The following is a description of a gene set: studied in species Mus musculus from publication Marson A, Kretschmer K, Frampton GM, Jacobsen ES, Polansky JK, MacIsaac KD, Levine SS, Fraenkel E, von Boehmer H, Young RA (PMID 17237765) Foxp3+CD4+CD25+ regulatory T (T(reg)) cells are essential for the prevention of autoimmunity. T(reg) cells have an attenuated cytokine response to T-cell receptor stimulation, and can suppress the proliferation and effector function of neighbouring T cells. The forkhead transcription factor Foxp3 (forkhead box P3) is selectively expressed in T(reg) cells, is required for T(reg) development and function, and is sufficient to induce a T(reg) phenotype in conventional CD4+CD25- T cells. Mutations in Foxp3 cause severe, multi-organ autoimmunity in both human and mouse. FOXP3 can cooperate in a DNA-binding complex with NFAT (nuclear factor of activated T cells) to regulate the transcription of several known target genes. However, the global set of genes regulated directly by Foxp3 is not known and consequently, how this transcription factor controls the gene expression programme for T(reg) function is not understood. Here we identify Foxp3 target genes and report that many of these are key modulators of T-cell activation and function. Remarkably, the predominant, although not exclusive, effect of Foxp3 occupancy is to suppress the activation of target genes on T-cell stimulation. Foxp3 suppression of its targets appears to be crucial for the normal function of T(reg) cells, because overactive variants of some target genes are known to be associated with autoimmune disease. Mouse Gene Set: MARSON_BOUND_BY_FOXP3_STIMULATED Genes with promoters bound by FOXP3 in hybridoma cells stimulated by PMA and ionomycin., and this is the list of marker genes: Ncoa3, H2bc21, Dgka, Ociad2, Cd3g, Ect2, Tnfrsf18, Hp1bp3, Marchf6, Fgl2, Ttc24, H3c8, Clec2d, Dbf4 (NCBI Gene Id 27214), Stat3, H2ac6, Eea1, Ly96, Znrf2, Kdm2b (lysine (K)-specific demethylase 2B), Fkbp1a, Hadhb, St13, Rps6ka5, Msh5, Leo1, Cntd1, Dtl, Mier1, Junb (NCBI Gene Id 16477), Coq10b, Nars2 (asparaginyl-tRNA synthetase 2 (mitochondrial)(putative)), H3c1, Lyrm4, H4c6, Tmem50a, Dap, Ctps1, Fbxw21, Anxa9 (NCBI Gene Id 93822), Cyp1a1, Ube2d3, Kif2c, Ubb, Epm2aip1 (NCBI Gene Id 77781), Ranbp10, Hsp90b1 (NCBI Gene Id 22027), Itgb7, Ndfip1, Lrr1, Cisd2 (CDGSH iron sulfur domain 2), Ern1, Cenpl, Rchy1, Wdr44, Kctd10, Hnrnpf, Nfatc2 (nuclear factor of activated T cells, cytoplasmic, calcineurin dependent 2), Usp17ld, Tmed2, Srpk1, Sytl2, Slc25a40, Gm5867, Slc26a8, Irag2, Snrnp35, H4c2, Tubg1, Cops7b, Tmed10, H4c8, Tradd, Adam10, Psme3ip1, AI504432, C1galt1, Fem1b, Zfp13, Tom1l2, 4933434E20Rik, Alyref, Gas5, Pofut1, Plin2, Letmd1, Ccni, Dipk1a, Nrip1, Zbtb11os1, Trp53, Camk1d, Limd2 (LIM domain containing 2), Mapre2, Rbl1, Orm1, Itk, Tmed5, Elavl1, Ttc5, Trim16, Atp10d, Themis (thymocyte selection associated), Acp2, Scnm1, Kifc5b, Ccr1, Fam216a, Snapc3, Frmd8, Zfp52, Rbm6, Spa17, Camk2g (calcium/calmodulin-dependent protein kinase II gamma), Reep3 (receptor accessory protein 3), Mcm3, Bin3, 2700097O09Rik, Tnfrsf19, H4c1, Mllt3, Eri2, Ubap2l, Retreg3, Dyrk1a, Trpc2, Kctd20, Stk26, Numa1, Nsfl1c, Gtpbp1, H2ac8, Lgals8, Slfn3, Mlec, Flad1, Pcsk1, Ccnd3 (cyclin D3), Bspry, Wdr6, Sema4a, Usp8, Mdm2, Lyrm1, H1f5, Fyn, Csf1, Psmb3 (NCBI Gene Id 99155), Gm5763, Ints12, Edem1, Ddx39a, Or8c16, Per1, Dnajc2, Cobll1 (NCBI Gene Id 319876, Cobl-like 1), Chek1, Pbrm1, Nckap1, Trappc5 (trafficking protein particle complex 5), Clip1, Sesn1, Smap2, Gck (glucokinase), Leprotl1, H3c14, Rest, Bbs12, Abhd2, Slc25a45, Fasl, Ndufv2, Slc37a3, Hnrnpa1, Acot2, Gpr35, Dclre1b, Nop58, Marchf9, Vps72, Tmem60, Dzip3, Rrp12, Oaz1, Enoph1, Psmc2, Trim44, Cstpp1, Stx16, Dennd1b, Apaf1, Jmjd6, Crtam, H2bc26, Sash3, Setd7, Vmn1r14, Ppat, Pdia3, Rheb, Ttc41, Adgre4, Klf6 (Kruppel-like transcription factor 6), Usp17lc, Tnfrsf9, Fam162a, Sephs1, Dclre1c, Hsd17b10, Smarcc1, Atg12, Ggta1, Rab8b, Dbr1, Ikbip, Ppie, Wdr31, Dynlt2a1, Sfr1, Tpgs2, Mink1, Traf3ip3, Myl4, Ms4a6b, Hmg20a, Ppp1r13b, Itih5, Ctsc, 4921524J17Rik, Erp27, Pde6d, Coa7, Ing3 (NCBI Gene Id 71777), Atl3, Tmem79 (NCBI Gene Id 71925), Zbtb1, Xpo1, Zc3hav1, Cdk4, Ell, Ccdc32, Usp48, Tnfsf4, Synj2, Ddias, Mfsd6, Kbtbd3, Gm14296, Mtmr1, Mdm1, Kdm5a, Mrpl36, Utp25, Tmem59, Nr1h3, H2ac22, Slc22a3 (NCBI Gene Id 20519), H3c7, H1f3, Cilk1, Cyp4f41-ps, Sypl1, Gcnt3, Map3k1, Fth1, Lipc, Arl5b, Trpc4ap, Kdm5b, Ssbp3, Dap3, Zfp36l1, Nap1l4, Flot1, Rilpl1, Slc17a6, Poglut3, Arid1a, Map2k6, Praf2, Ube3b, Supt20, Birc3, Ddit4, Herpud2, Zbtb25, Eif4e, Gimap5, Zbtb37, Pou2f3, Btbd35f7, Cab39, Nrbp1, Aqp9, Evi2b, Slc2a1, Eya2, Thumpd3, Zfp426, Nabp1, Tpst2, Tceanc2, Itgal, Hsf4, Acsl4, Ramp1, Ubb-ps (ubiquitin B, pseudogene), Pms1, Ier3, Gm5865, Ptbp3, Evi2a, Saraf, Bltp3b, Ash1l, Fars2, Six6, Wbp11, Polg2 (NCBI Gene Id 50776), Xrcc4, Plcd1, Cd72, Vtcn1, Dsg2, Fam135a, Samd13, Cited2, Rspry1, Herc4, Cbx7, Nr1d1, Kcnn4, Ermard, Pou2af1, Ptger1, Cnot2, Arih2, Pmpca, Tesk2 (testis-specific kinase 2), P2rx4, Prr13, Prune1, Rgs3, Ccdc18, Gpr18, Izumo1r, Dync2i1, Ccdc77, Samd4b, Cfap43, Commd3, Efcab2, Slc3a2, Tmod3, Arl6ip6, Dixdc1, Snai3, Grap, Cpd, Uba3, Il2, Plg, Eapp, H4c3, Gstt2, Rnf170, Mrgpra2b, Gbp8, Wrap53, Zfand6, Xbp1, Cdk19, H3c10, Rab19, Psen1, Xlr5d-ps, Avpi1, Tiparp, Ubxn8, H2ac4, Arf2, Atp5if1 (ATP synthase inhibitory factor subunit 1), Tbce, BC049715, Cutal (cutA divalent cation tolerance homolog-like), Utp6 (NCBI Gene Id 216987), Srp54a, Gpr171, Slc20a1, Rgs1, Pimreg, Cers2, Pmvk, Cep57l1, Dnai4 (NCBI Gene Id 242584), Gatb, Gm9991, Gtf2a2 (general transcription factor II A, 2), Arhgdib, Picalm, Mrpl34, Crot, Rnf115, Rcc2, Tes, Ints13 (integrator complex subunit 13), Actrt3, Ube2r2 (NCBI Gene Id 67615), Insig1, Mindy3, Bbs4, Mettl5, Bcar1, Ssmem1 (serine-rich single-pass membrane protein 1), Usp17la, Prpf40a, Slc25a24, Gpd2, St8sia4, Hspa4l, Dlec1, H2ac7 (H2A clustered histone 7), Rap1a, Elk4, Slc49a4, Glce, Mageb3, Eid1, Cish, Kcna3, Usp4, Tor1aip1, Usf1, Irf2, Psmd5, H4c4, Cd53, Pecam1, Mettl13 (NCBI Gene Id 71449), Grap2, Ago2, Slc35b4, Tnpo1, Ly6a, Mgme1, Fam133b, Josd1, Ercc1, Dhfr, Prdx1, Rel, Eml4 (echinoderm microtubule associated protein like 4), Slc6a4, Zfand5, Wasf2, Srpk2, Eif5, Rsrp1, Tle3, Sesn2, Tmem164 (transmembrane protein 164), Gm1818, Nup58, Park7, Etv3, Fyb1, Rad54l2, Cfap418, Stap1, Tshz1, Rock2, Dram2, Ykt6, Adipoq, Ets1, Golph3, Arhgap12, Arhgef12, Gabpb1, Rtn3, Gm5242, Trim17, Dapp1, Pim1, Ubr1, Prrc2a, Arg2, Gm5537, Bmi1, Meig1, Cyld, Tsnaxip1, Rbpj, Hook3, Lrif1, Dmac1, Nedd9, Abcb8, Snapc4, Stk11ip, Ythdf3 (YTH N6-methyladenosine RNA binding protein 3), Alg9, Cbln3, Zc3h12d, Chic2, Fah, Rps26, Fgr, Coa3, Lrrc25, Ptger4, Entr1, Mfsd14a, H4c18, Slc41a1, H2bc22, Akirin1, Tlcd2, Kpna3, Slc36a1, Ubald2, Ncf1 (NCBI Gene Id 17969), Septin6, Tmem53, Snrnp25, Oacyl, H2ac20, Tmem167, Tbl1x, Slc25a33, Fgf2os (NCBI Gene Id 329626), Thy1, Syf2, Rpusd2, Metap1, Itprip, Ahcyl1, Nup210 (NCBI Gene Id 54563), Fip1l1, Mbnl1, Ccr3, Peak1, Pip5k1a, Zfp1, Pdk1, Tmem71, Susd6, Abhd8, Glyat, Cog3, Cgas, Faf1, Rgs2, Aasdhppt, Dnase1, Jaml, Mrpl42, Fam98b, Cxcl10 (NCBI Gene Id 15945), Zfp472, Cfap68, Trat1, Nrdc, Tial1, Zwint, Bach1, Shisa5, H3c11, Gstm7, Tex19.1, Dhrs9, Iscu, Lyset, Eloa, Adm, Tnfsf14, Hnrnpul1, Nasp, Vps26c (VPS26 endosomal protein sorting factor C), Stat6, Rab2a, Cryab, Eif4enif1, Aqp11, Sgpp1, Plscr2, Ndufs6, Npb, Ppp2r1a, Got2, Atm, Lix1, Npat, Or12j3, H2bc9, Tgoln1 (trans-golgi network protein), Ly9, Senp1, Lrrc8d, Kat2b, Slc25a15, Cxcr5, Orc5, Acot1, Nup153, Zap70, Scp2, Bcl10, Ube2d2b, Npc1, Plgrkt, Frg2f1, Cmpk1, Smg7, Kat2b-ps, Hspbap1, Nrgn, Gbp2, Cip2a, Mad2l1bp, Pdcd2 (NCBI Gene Id 18567), Ell3, Aggf1, Il10ra, Lst1, Arhgap11a, Elovl5, A130010J15Rik, Cept1, Cdk17, Fbxo48, Egr2, Prmt5, Or9r3, H2ac11, Cmtm7, Kif5b, Rnmt, H4c9, Bloc1s5, Aftph, Mindy1, Sars1, Timm21, Alg8, Tnfrsf1b, Pfkm, Ptprc, Actbl2, Ccr4, Arl6ip5, Msh3, H2bc12, Epc2, Fgf7, Pikfyve, Ddb2, Dars2, Ccpg1, Cdyl2, M1ap, Atg9b, Lsm10 (U7 snRNP-specific Sm-like protein LSM10), Fbxo9, Cdc40, Hspa13, Lctl, Dcaf1 (DDB1 and CUL4 associated factor 1), Slfn2, 4833439L19Rik, Rhbdd3 (NCBI Gene Id 279766), Srsf3, Vamp4, S100a6, Lcp2, Serinc1, Ccng2, Nsun6 (NOL1/NOP2/Sun domain family member 6), Zfp280d, Ppp2r5a, Akr1c13, Pym1, Arih1, Atp5pd, Ube2v1, Ube2g2, Polr3c, Ptprj, Slc25a12, Kti12, Epb41l2, Khnyn, Tbrg1, Khdc4, Glipr1, Slc9a9, Foxj3, Aph1a, Entpd5, Mettl6, H4c14, 5330438D12Rik, Rabgap1l, Wdr59, Gpn3, Cd47, Mapkapk3, Ubl3 (NCBI Gene Id 24109), Sdcbp, Trim12c, Cytip, Tmem62, Hectd2, Frmd6, Aplp2, Fam72a, Orai2, Cad, Sart3, Zpbp2, Hnrnpu, Wdr45, Ubxn4, Atosa, Ap4b1, Mrpl45, F2rl2, Arid5b, Hcst, Tmem167b, Prcc, Tbk1, Hhat, Phaf1, H3c13, Ggnbp2, P2ry10, Mlh1, Nptn, Cdc27, Ucp2 (NCBI Gene Id 22228), Os9, Lysmd1, Taf8, Brms1l, Psmd4, Arl10, Adh1, 4930539J05Rik, H2ac12, Kpnb1, Rps29, Pcgf2, Srsf1, H4c11 (H4 clustered histone 11), Fcgr4, Crygs, Saxo2, A930024E05Rik, Tollip, Pop5, Pcmt1, Il2ra, Map4k4, Me1, Mrps31, Mix23, Dnaja2, Usp3, Brca1, Dnajb14, Nup43, Gm5946, Aipl1, Fyttd1, Tcp11l2, Prdx6, Abhd1, Abhd13, Efl1, Pdcd1, Ube2d1, Map3k5, Lcorl, Scarb2, Polr3b, Cul3, Dnajb12, Scfd2, Ccdc117, Arpc1b, Zbed5, Smg5, Ece1, Cx3cr1, Mrpl33, Slc5a6, Tnfrsf26, Prrg4, Setd5, Armc8, Ppp4r1, Art2b, Rbl2, Kdm6a, Letm2, Xpa, Serf2, Ltb, Fubp1, Dusp6, Rpl27a-ps4, Mphosph8, Liph, Creb1, Cap1, Gtpbp2, Mefv, Rubcn, Babam2, H4c12, Glo1, Tmem134, Stx7, Herc1, Arhgef6, Zfp281, Gpr22, Urm1, Nbr1, Ctdspl2, Clic1, Riox2, Cd3d, Bloc1s6, Eaf1, Paics, Rnf121, Txn1, Ifnk, Sugct, Lnpep, Smad7, Rhoa, Dnaaf11, Kansl2, Blcap, Ncapd3, Tcta, Sil1, Syne3 (spectrin repeat containing, nuclear envelope family member 3), Tceal9, Dpysl2, Gstcd, Ssbp4, Gsap, 1700055D18Rik, Amz2, Ppp1cb, Catsper2, Sipa1l1, Fam185a, Mapk6, Cgref1, Cela1, Ly6c1, Nfatc3, Etf1, Igsf8, P2ry10b, Antxr2, Ctsd, Lrp10, Cenpa, H4c16, Tfb2m, Gm5069, Chmp4b, Sun2, Ptpn22, Usp10, Slc35f6, Gpat4, Bzw2, Synrg, Wdr26, Ccl1, Mcl1, Rcl1, Ttll12, Fam43a, Ogt, H3c15, Eola1, H3f4, Tbl1xr1, Gng2, Cstb, Topbp1, Lypla2, Atp1a2, Tmem209, Slc39a10, Zbtb22, H3c6, Cd3e, Nrp1, Ifi204, Mtrf1l, Idh1, Hsph1, Csnk1g2, Paip2, Il9r, Nfkbid, Lrrc27, Cenpc1, Tor1aip2, Cd28, Osbpl8, Rhog, Riok2, Atp6v0a1, Asph, H2ac25, Fbrs, Hadha, Lrrc58, H2az1, Nfia, Shc1, Sdf2, Hook2, Vps37b, Glt8d2, Rida, S100a5, Cd2, Ecpas, H3c4 (H3 clustered histone 4), H2ac13, Pramel3c, Pgk1, H3c3, Osbpl9, Myc, Dda1, Slc23a2, Cep120, Tab2, Cetn4, Gtf3c6, Armc6, H2ac18, H3c2, Fbxw10, Hnrnpdl, Arhgap10, Pold3, Ccn2, Slc11a2 (solute carrier family 11 (proton-coupled divalent metal ion transporters), member 2), P4ha3, Golph3l, Kdm5c, Csrnp1, Selenoi, Spred2 (NCBI Gene Id 97717), Irf8, Oaf, Sgk1, Ndufaf3, Spata6, Gmfg, Supt6, Cnot6l, Nfat5, Sh2b3, Atxn1, Cenpi, Chd1, Mup1 (NCBI Gene Id 17840), Hcls1, Smim14, A930012O16Rik, Skil, Cd274, Lysmd3, Noct, Anapc11, Srxn1, Apbb1ip, Gm14367, Dennd4a, Srrm2, Akirin2, Samsn1, Mto1, Setdb1, Spag9, Nt5e, Wsb2, Ube2n, Zbtb5, Rab3gap1, Angptl4, Zdhhc9 (zinc finger, DHHC domain containing 9), Pllp, Polr1e, Dynlt4, Gpr146, Chd1l, Wfs1, Gm4992, Gpr65, Pold4, Tmem30a, Mat2b, Tmem19, Rbks, Zfp330, Siae, Snx30, Add1, Gadd45b (growth arrest and DNA-damage-inducible 45 beta), Itm2b, Nek7 (NIMA (never in mitosis gene a)-related expressed kinase 7), Tgif1, Dnajc8, Ppt1, Zfp3, Gm5925, Usp6nl, Phtf2, Jak2, Cdkn1b, Dut, Fhip1b, Or9r7, Lpxn, Epcip, Mfsd11 (major facilitator superfamily domain containing 11), Ptgr3, Nat9, Tmprss4, Asf1a, Abhd12, Gm5780, Dcun1d3 (defective in cullin neddylation 1 domain containing 3), Ankmy2, Rnf11, Fhl2, Gypc, Ppef2, H2ac24 (NCBI Gene Id 319171), Pnrc2, Arl11, Cga, Csk, Gm5420, Gfpt1, Xpnpep3, H2ac19, Bnip2, Anxa7, Dnajb4, Gm4928, Adora2a, Tomm34, Cbx3, Cabp1, Gsr (NCBI Gene Id 52270), Car12, Srgn, Lrp2bp, Mrps28 (mitochondrial ribosomal protein S28), Mup2, Mynn, Ube2w, Fam107b, Mplkip, Cpsf2, Ormdl1, Cxcr6, Apba2, Tnip3